The following is a description of a gene set: Any process that mediates the adoption of a specific fate by a cell. species: Homo sapiens Human Gene Set: GOBP_REGULATION_OF_CELL_FATE_SPECIFICATION, and this is the list of marker genes: HDAC1, FZD7, SOX17, MTA2, FGF2, MBD3, CHD3, FGFR1, GATAD2B, MESP1, WNT3A, BMPR1A, SFRP2, LMO4, RBBP4, MTA1, HDAC2, CHD4, DKK1, MTA3, RBBP7, ESRP1, GATAD2A